The following is a description of a gene set: species: Mus musculus Any process that stops, prevents or reduces the frequency, rate or extent of amyloid precursor protein catabolic process. Mouse Gene Set: GOBP_NEGATIVE_REGULATION_OF_AMYLOID_PRECURSOR_PROTEIN_CATABOLIC_PROCESS, and this is the list of marker genes: Apoe, Pin1, Tmed10, Pin1rt1, Bin1, Spon1 (NCBI Gene Id 233744), Ntrk2, Sorl1, Rtn4, Prnp, Rtn2, Rock1, Gga3, Abca7, Hap1, Clu, Rtn1, Rps23rg1, Rtn3, Igf1, Flot2